The following is a description of a gene set: Any process that stops, prevents or reduces the rate or extent of antiviral mechanisms, thereby facilitating viral replication. Mouse Gene Set: GOBP_NEGATIVE_REGULATION_OF_DEFENSE_RESPONSE_TO_VIRUS species: Mus musculus, and this is the list of marker genes: Itch, Rnf26, Tarbp2, Htra1, Trim38, Igtp, Rnf26rt, Pcbp2, Nt5c2, Mul1, Irgm1, Irgm2, Ppm1b, Fgl2, Ilrun (inflammation and lipid regulator with UBA-like and NBR1-like domains), Atg5, Foxp3, Atg12, C1qbp, Traf3ip1